The following is a description of a gene set: species: Homo sapiens Human Gene Set: GOCC_PSEUDOPODIUM A temporary protrusion or retractile process of a cell, associated with flowing movements of the protoplasm, and serving for locomotion and feeding., and this is the list of marker genes: ARRB1, F2RL1, LDB3, VAMP7, MAPK1, MSN, RAB25, RAF1, KLHL41, ACTN1, ACTN3 (actinin alpha 3), MAPK3, PLA2G6, CAPN2, ACTN4, ACTN2, MYOZ1